Given this list of marker genes EXOSC3, EXOSC9, EXOSC2, EXOSC7, EXOSC8, ERI1, EXOSC10, here is a description of the gene set: Exonucleolytic digestion of a pre-rRNA molecule to generate the mature 3'-end of a 5.8S rRNA molecule derived from an originally tricistronic pre-rRNA transcript that contained the Small Subunit (SSU) rRNA, the 5.8S rRNA, and the Large Subunit (LSU) rRNA in that order from 5' to 3' along the primary transcript. studied in species Homo sapiens Human Gene Set: GOBP_EXONUCLEOLYTIC_TRIMMING_TO_GENERATE_MATURE_3_END_OF_5_8S_RRNA_FROM_TRICISTRONIC_RRNA_TRANSCRIPT_SSU_RRNA_5_8S_RRNA_LSU_RRNA